Given this list of marker genes Atf4, Rragd, Fas, Rnf167, Ucp2, Nprl3, Sar1a, Rraga, Cdkn1a, Gcn1, Eif2ak4, Sh3glb1, Impact, Eif2ak3, Dap, Eif2s1, Nprl2, Depdc5, Pex2 (peroxisomal biogenesis factor 2), Map3k5, Map1lc3a, Wdr24, Sesn3, Rnf152, Eif2ak2, Trim32, Rragb, Wdr59, Atf3, Sesn2, Prkch (protein kinase C, eta), Slc38a2, Szt2, Mios, Eif2b1, Mapk3, Mtor, Flcn, Rragc, Castor1, Mapk1, Becn1, Mapk8, Seh1l, Atf2, Larp1, Sar1b, Lars1, Tfeb, Sesn1, Kics2, Eif4ebp1, Bmt2, Itfg2, Gpr155, Atxn3, Ulk1, Eif2a, Kptn (kaptin), Prkd1, here is a description of the gene set: Mouse Gene Set: GOBP_RESPONSE_TO_AMINO_ACID_STARVATION Any process that results in a change in state or activity of a cell or an organism (in terms of movement, secretion, enzyme production, gene expression, etc.) as a result of deprivation of amino acids. studied in species Mus musculus